Given this list of marker genes HNRNPK, RECQL4, TCOF1, AHDC1, RNU12, KRAS, ERF, MASP1, FGFR2, PIGT (NCBI Gene Id 94004), BMP4, IL11RA, ZIC1, RAC3, POR, SEC24D, TWIST1, SLC4A10, RAB23, here is a description of the gene set: A kind of craniosynostosis affecting the lambdoidal suture. Human Gene Set: HP_LAMBDOIDAL_CRANIOSYNOSTOSIS Lambdoidal craniosynostosis studied in species Homo sapiens